Given this list of marker genes Kit, Nr4a3, Fcer1a, Fcer1g (NCBI Gene Id 98395), Syk, here is a description of the gene set: species: Mus musculus Any process that activates or increases the frequency, rate, or extent of mast cell cytokine production. Mouse Gene Set: GOBP_POSITIVE_REGULATION_OF_MAST_CELL_CYTOKINE_PRODUCTION